Given this list of marker genes PPFIA2, RB1, SKIL, GPM6B, RGS7BP, NEUROD1, PPP1R3A, WIF1, OXR1, SH3TC2, AEBP2, IPO7, SPAG17 (sperm associated antigen 17), SDHAF3, KRTAP9-3, DLGAP1, ODR4, BLVRB, RBKS, IQGAP3, ROCK2, CHRNA9, TSHZ2, DDX3X, BHLHE40, FAM171B, PALB2, OMG, TFPI, SEPTIN8, JAM3, NEK1, WWP2, DYNC1LI2, PDZD8, ZNF317, TASOR, MTSS1, COPZ1, SACS, ALDH1A3, SNX31, IGSF3, DEK, RAB6A, ZNF236, PIK3R6, STXBP5, EPAS1, NEK7, SMC3, FRRS1L, KANSL1L, PABIR1, PLAC9, COL8A1, CADM2, GATM, RAB21, RGL1, FSCN1, FBXW11, KPNA3, NRP1, LXN, HIPK3, HNRNPR, TAF7, CTNNA3, HCFC2, PDE3A, VPS13B, SHC3, UBE2E2, LYSMD3, PEF1, TNIP1 (NCBI Gene Id 10318), CDH11, CTNND2, CPSF6, RPE, RAPGEF2, BEND4, SATB1, RGN, ZNF584, ZFPM2 (zinc finger protein, FOG family member 2), ANKRD44, here is a description of the gene set: studied in species Homo sapiens Genes predicted to be targets of miRBase v22 microRNA hsa-miR-127-5p in miRDB v6.0 with MirTarget v4 prediction scores > 80 (high confidence targets). Human Gene Set: MIR127_5P from publication Chen Y, Wang X (PMID 31504780)